The following is a description of a gene set: The switching of activated B cells from IgM biosynthesis to IgE biosynthesis, accomplished through a recombination process involving an intrachromosomal deletion between switch regions that reside 5' of the IgM and IgE constant region gene segments in the immunoglobulin heavy chain locus. species: Mus musculus Mouse Gene Set: GOBP_ISOTYPE_SWITCHING_TO_IGE_ISOTYPES, and this is the list of marker genes: Clcf1 (NCBI Gene Id 56708), Ndfip1, Bcl6, BC037156, Stat6, Il4, Foxp3, Tnfsf4